Given this list of marker genes Ctns, Cyba, Sod2, Duox2, Mpv17l, Cyp1a1, Duoxa2, Duoxa1, Sod1 (NCBI Gene Id 319325), Acox1, Ncf1, Cybb, Abcc1, Mfn2, Nox4, Cyp1a2, Stat3 (NCBI Gene Id 68733), Zfp13, Duox1, Fyn, here is a description of the gene set: studied in species Mus musculus Mouse Gene Set: GOBP_HYDROGEN_PEROXIDE_BIOSYNTHETIC_PROCESS The chemical reactions and pathways resulting in the formation of hydrogen peroxide (H2O2), a potentially harmful byproduct of aerobic cellular respiration which can cause damage to DNA.